Given this list of marker genes Specc1, Eif2b1, D130043K22Rik, Astl, Itm2c, Nip7, Snx27, Spock1, Ckap5, Dars2, Bzw2, Ankfy1, Sh3bgrl3, Wdfy3, Plekhd1, Rab5c, Adgrg2, Xdh, Wdr33, Fbxo41, Stoml1, Adcy1, Sowahb, Lrfn2, Gpr151, Adprh, Kbtbd2, Zfp874b, Nars2, Dlk1, Idi2, Ceacam9, Rab5b, Zfp488, Nploc4, Acta1, Tbx10, Ednrb, Nfkb1, Stac2, Foxi1, Cldn2, Gpr161, Ifnlr1, Slc25a25, Kcnj8, Fgf10, Slc15a1, Cyp2c65, Ppp2r5a, Sh3rf2, Bcl2, Naa11, Setd5, Parpbp, Mrps34, Bptf, Cspp1, Tbc1d22a, here is a description of the gene set: Genes predicted to be targets of miRBase v22 microRNA mmu_miR_5627_3p in miRDB v6.0 with MirTarget v4 prediction scores > 80 (high confidence targets). from publication Chen Y, Wang X (PMID 31504780) species: Mus musculus Mouse Gene Set: MIR_5627_3P